The following is a description of a gene set: species: Mus musculus Enables the transfer of glycine from one side of a membrane to the other. Glycine is aminoethanoic acid. Mouse Gene Set: GOMF_GLYCINE_TRANSMEMBRANE_TRANSPORTER_ACTIVITY, and this is the list of marker genes: Slc32a1, Slc7a8, Slc38a1, Slc36a2, Slc6a9, Slc6a5, Slc36a1, Slc38a5, Slc36a3, Slc25a38